Given this list of marker genes NEO1, UBE2J1 (NCBI Gene Id 51632), ENY2, PKDCC, WWP2 (NCBI Gene Id 116013), ANGPT1, PPM1F, YOD1, FAM3D, GHSR, GDI1, DERL3, NDFIP2, MIR30C1, SP100, TERF1 (NCBI Gene Id 7013), KCNB1, SYT4, SNX12, OS9, PKIA (NCBI Gene Id 5569), MAPT, HDAC3, CCN3, RAB11FIP3, MIDN, INPP5K, GNAI1, APOD, USP17L2, NDUFAF2, ITGB1BP1, KCNE1, MIR19B1, RHBDF1 (rhomboid 5 homolog 1), RHBDF2, DPH3, MIR29B1, SERGEF, CYP51A1, PDE8B, CHP1, CDK5, PTPN11, SVIP, PRKN (parkin RBR E3 ubiquitin protein ligase), VSNL1, FERMT1, FOXO1, SIAH3, PKIG, REST, SNX3, PIM3, IL1B, MIR199A1, ERLEC1, HADH, SUFU, DNAJA1, IDH2, MIR148A, YWHAB, OPRM1, KCNJ11, IRS1, FFAR2 (free fatty acid receptor 2), ADRA2C, F2R, CD200, ACVR1C, MIR19A, INS, FRMD4A, SYTL4, MIR128-1, NPFF (NCBI Gene Id 8620), PFKL, INHBB, RAB11FIP1, GNAZ, NDFIP1, NFKBIA (NFKB inhibitor alpha), LRRK2, GHRL, UCP2, DRD2, KLF7, BMP8A, JAGN1, TXN, NF1, LMAN1, MIR93, HMGCR, FKBP1B, F2RL1, MDFIC, ADIPOQ, ERP29, SUMO1, CORO2B, CHGA, NR1H3, UBE2G2, UFM1, PSMD9, BARD1, ADRA2A, LYPLAL1, C11orf65 (chromosome 11 open reading frame 65), CD36, RAB23, CABP1, DRD3 (dopamine receptor D3), INSIG1, UBAC2, BAG4, MIR766, APOE, EI24, ABCC8, IL12A, SIRT4, DMTN, DRD4, LYPLA1, RSC1A1, RAB11FIP5, ANXA13, FAM76B, SIRT6, DERL2, GNAO1, BAG3, RSAD2, CSK, MTNR1B, IL12B, ADTRP, RANGAP1, MIR146A, SREBF1, PARK7 (Parkinsonism associated deglycase), here is a description of the gene set: species: Homo sapiens Any process that stops, prevents or reduces the frequency, rate or extent of establishment of protein localization. Human Gene Set: GOBP_NEGATIVE_REGULATION_OF_ESTABLISHMENT_OF_PROTEIN_LOCALIZATION